Given this list of marker genes VDAC1, SLC25A4, BAX, SLC25A31, PPIF, SPG7, SLC25A5, here is a description of the gene set: Human Gene Set: GOCC_MITOCHONDRIAL_PERMEABILITY_TRANSITION_PORE_COMPLEX A protein complex that connects the inner and outer membranes of animal mitochondria and acts as a pore that can open transiently to allow free diffusion of solutes between the mitochondrial matrix and the cytosol. The pore complex is formed of the voltage-dependent anion channel (VDAC), the adenine nucleotide translocase (ANT) and cyclophilin-D (CyP-D). studied in species Homo sapiens